Given this list of marker genes Lck, Rac2, Pik3r5, Pdpn, Cdc42, Col1a2, Pdpk1, Rhob, Fyn, Pik3r2, Vav1, Lcp2, Ptpn6, Plcg2, Syk, Lat, Mpig6b, Pik3cb, here is a description of the gene set: This event has been computationally inferred from an event that has been demonstrated in another species.<p>The inference is based on the homology mapping from PANTHER. Briefly, reactions for which all involved PhysicalEntities (in input, output and catalyst) have a mapped orthologue/paralogue (for complexes at least 75% of components must have a mapping) are inferred to the other species. Reactome Pathway: GPVI-mediated activation cascade electronically inferred by orthology from the curated human pathway species: Mus musculus part of: Platelet activation, signaling and aggregation